The following is a description of a gene set: Binding to Hsp90 proteins, any of a group of heat shock proteins around 90kDa in size. species: Mus musculus Mouse Gene Set: GOMF_HSP90_PROTEIN_BINDING, and this is the list of marker genes: Bmal1, Tsc2, Hdac6, Hif1a, Stub1, Chordc1, Usp19, Ppid, Gucy1b1, Rps3, Ago2, Hdac8, Npas2, Eif2ak3, Erbb2, Cdc37, Nos2, Nup62, Ptges3, Ttc4, Ptges3l, Tsc1, Ern1, Unc45a, Kpnb1, Cd24a, Gbp2b, Slc12a2, Nod2, Unc45b, Ulk1, Nos3, Fkbp6, Ppp5c, Arhgdia, Cyp1a1, Ahr, Ppef2, Cyp2e1, Ahsa1, Hsf1, Gbp2, Ksr1, Ptges3-ps, Telo2, Mapt, Stip1, Pacrg, Cdk5r1, Nr3c1 (NCBI Gene Id 14815), Cyp2b10 (NCBI Gene Id 13091), Cdk5